Given this list of marker genes Epas1, Cited2, Ep300, Hif3a, Hif1a, here is a description of the gene set: Reactome Pathway: Regulation of gene expression by Hypoxia-inducible Factor This event has been computationally inferred from an event that has been demonstrated in another species.<p>The inference is based on the homology mapping from PANTHER. Briefly, reactions for which all involved PhysicalEntities (in input, output and catalyst) have a mapped orthologue/paralogue (for complexes at least 75% of components must have a mapping) are inferred to the other species. species: Mus musculus electronically inferred by orthology from the curated human pathway part of: Cellular response to hypoxia